Given this list of marker genes LRP5, DYNLL1, GJB6, MIR146A, TRPM4, PDE8B, PTPRN, STXBP4, OSBP, PCK2, ERN1, UCP2, RFX6, GCLM, NUCKS1, SIDT2, PIH1D1, NCF1, HK3, SMAD3, MIR337 (NCBI Gene Id 442905), GAS6, LRRC8D, SYBU, TGFB1, ADCY8, GATA4, SMARCA4, RAC1, GCKR, TRA2B, RBM4, CYBA, CRH, PRKACA, SRF, FOXK2, GCG, C2CD2L, FIS1, SIN3A, NOX4, MIR320C2, IGF1, PTPRN2, OXCT1, SOX4, PAX2, SLC29A1 (solute carrier family 29 member 1 (Augustine blood group)), SIRT1, FUT1, GPRC6A, SLC39A14, CDK16, SMAD4, CASR, GHRHR (NCBI Gene Id 2692), ICAM1, PIM3 (NCBI Gene Id 415116), GHRL, JAGN1, FOXA3, ZBTB20, NDUFAF2, PPP3CB, CFTR (CF transmembrane conductance regulator), SELENOT, FOXA2, MIR15A, IRS2, HKDC1, ADCY5, SLC12A6, CLTRN (collectrin, amino acid transport regulator), NADK, LIN28A, IGF1R, C1QTNF12, RPTOR, COL1A1, PDX1, PPARGC1A, UNC13B, TREM2, PRKN, RAB11B, MIRLET7G, MIR320D2 (microRNA 320d-2), BAD, SLC2A2, RACK1, MIR103A1, PRKAA2, PRKCE, SERPINF1, ENDOG, GCLC, STXBP3, HK1, GCK, PPARD (NCBI Gene Id 5467), PIK3R1, STX4, GPR68, RAF1, SMARCB1, NPTX1, GPER1, GPLD1, XBP1, OPRK1, ANO1, SLC9B2, PCK1, MIR320B1, EFNA5, FOXO1, LRRC8A, ABCA12, AGER, GPX1, SLC12A7, KLF15, HLA-DRB1, MIR320B2, ADRA2A, MIR320D1, TRPM5, VSNL1, PRKAA1, TUNAR, CMA1, ZNF236, PLA2G6, RAB11FIP5, ABCC8, BRSK2, FKBP1B, KCNK16, RAB11FIP2 (RAB11 family interacting protein 2), GPR27, PIK3CA, USF1, KCNB1, MIR320E, CCDC186, CARTPT, USF2, TRPA1, NKX6-1, MPC2, CYP7A1, FOXO3, MIR16-1, MIR320A, NR1H4, MIR320C1, SRI, HK2, HIF1A, BAIAP3, OGT, PIK3R2, KAT5, PHPT1, UBTF, MLXIPL, NGFR, EPHA5, ZBED6, NR1D1, FOXK1, KLF7, ENY2, here is a description of the gene set: studied in species Homo sapiens A homeostatic process involved in the maintenance of a steady state level of glucose within a cell. Human Gene Set: GOBP_INTRACELLULAR_GLUCOSE_HOMEOSTASIS